Given this list of marker genes BRCC3, ZNF577, GABPA, ARHGEF33, GBP2, TMCC1, PHF20L1, RAB10, NARS1, USP38, MAN1A1, ENPP1, AFF4, CHRDL1, CTLA4, FUCA2, SPRED1, SLC2A14 (solute carrier family 2 member 14), CCNJ, RRAS2, KLF7, WDR11, C2CD6, SEC61A2, ACER2, TNFSF8, PIK3C2A, USP9X, NKAIN1, C11orf96, ZNF827, STARD3NL, NR2C2, SC5D, VIP, ADD3, SLC38A9, SMARCAD1, PYCR2, RABEP1, BTBD1, RTKN2, GUCY2C, NPAT, OPRM1, TFDP1, GHR, SEC14L1, SLC39A14, FNDC3A, GOLGA6L10, GATAD2B, CENPI (NCBI Gene Id 2491), VCAN, SEMA3A, SLC1A1, MKX, SLC28A3, FASLG, PDK4 (NCBI Gene Id 5166), PKP2, TMEM212, STXBP6, DIP2B, AGPAT3, HDX, WAPL, SMPDL3B, LDLRAD3, PTPN20, ZNF322, LYSMD3, STARD4, ZFHX4, ZNF572, CNOT7, KLHL23, TAB3, CALCR, GNPDA2, USP1, CNTN1, CREB5, CPEB4, SH3GLB1, LRRN1, TRMT13, CADM2, NDRG3, GRIN3A, TMEM100, NECAP2, PHAF1, ARL13B, SRPK1, PKHD1, GLUL, ZNF160, IRF2, BLTP3A, EPHA3, SOX10, KIF2A, ERBIN, MZT1, TAF4, HNRNPLL, LECT2, RAB11A, MS4A6A, GRB2, GPC6, GLIPR1L1, SLCO4C1 (solute carrier organic anion transporter family member 4C1), POLR3F, TAGAP, POU2F3, LDB3, NRIP1, UHRF1, CTCFL, MON2, POLG, ODF2L, here is a description of the gene set: species: Homo sapiens Genes predicted to be targets of miRBase v22 microRNA hsa-miR-4424 in miRDB v6.0 with MirTarget v4 prediction scores > 80 (high confidence targets). from publication Chen Y, Wang X (PMID 31504780) Human Gene Set: MIR4424